Given this list of marker genes PIEZO1, NOTCH1, SERPINC1, CTNNB1, SLC4A1, MET, PIGM, JAK2, KCNN4, here is a description of the gene set: Thrombosis of the portal vein and/or its tributaries, which include the splenic vein and the superior and inferior mesenteric veins. Human Gene Set: HP_PORTAL_VEIN_THROMBOSIS species: Homo sapiens Portal vein thrombosis